Given this list of marker genes TERF1, TERF2, POT1, RPA1, HNRNPA2B1, NABP2, HNRNPA1, TERF2IP, CTC1 (CST telomere replication complex component 1), RPA2, here is a description of the gene set: Binding to G-rich, single-stranded, telomere-associated DNA. species: Homo sapiens Human Gene Set: GOMF_G_RICH_STRAND_TELOMERIC_DNA_BINDING